Given this list of marker genes 2510009E07Rik, BC005624, Wwp1, Thap2, Ccnt2, Cdh19, Eri2, Tmem164, Kif14, Rprm, Fadd, Casp7, Kcnj4, Arhgap12, Gata5, Trim59, Zfp654, Glb1l, Aasdhppt, Sp1, Kat7, 9030624G23Rik, Poglut1, Haspin, Commd2, Zfp467, Zfp113, Mob3c (NCBI Gene Id 100465), Adat1 (NCBI Gene Id 30947), Fbxo8, Alpk3, Med21, Hoxd8, Stag1, Fbxw27, Map3k2, Fam120c, Gm8817, Mrps36, Rbm12b2, Nrxn1, Kdm4c, Arhgap28, Gm4925, Tmem184c, Lhfpl4, Lhx9, Gzf1, Prss46, Lamp2, Hipk1 (NCBI Gene Id 68849), Mapk11, Map6, Usp6nl, Unc119b, Klhl15, U2surp, Ahsa2 (NCBI Gene Id 68883), Nt5dc3, Rab11b (RAB11B, member RAS oncogene family), Prss54, Klhl28, Chfr, Hand1, Plekhg5, Rasa1, Trim26, Slc17a6, Fam107b, C4bp, Zfp180, Ifit3, Catspere2, Scara5, Pdhx, Sorcs1 (NCBI Gene Id 58178), Tpst1, Daam1, Prss35, Shisa2, Il7, Cacna1b, Yod1, Fads1, Itsn1, Nckap5, Kmt5a, Rab3c, Glyr1, Rbm7, Tktl1, Zcchc4, Slamf6, Psd3, Sirt4, Frs2, Ippk, Usf3, Lig3, Zdhhc8, Dclre1b, Slc15a5 (solute carrier family 15, member 5), Serf2, Cyb5d2, Uqcc4, Calu, Trem1, Rock1, Prkaa2 (NCBI Gene Id 66516), here is a description of the gene set: from publication Chen Y, Wang X (PMID 31504780) Mouse Gene Set: MIR_335_5P species: Mus musculus Genes predicted to be targets of miRBase v22 microRNA mmu_miR_335_5p in miRDB v6.0 with MirTarget v4 prediction scores > 80 (high confidence targets).